Given this list of marker genes FAS, NTHL1, AAGAB, PPM1D, CHEK2, MRE11, MEFV (NCBI Gene Id 4210), BAP1, KLLN, LMNA, TWIST1, RAD51D, ATM, MITF, HMMR, PRKAR1A, RAD50 (NCBI Gene Id 10111, RAD50 double strand break repair protein), PTEN, USF3, PTPN6, MSH6, AXIN2, CTNNB1, MGMT, TGFBR2, SDHD, SEC23B, RABL3, NF1, GNAS, PALB2, ACD, ESR1, MSH3, ATR, CDK4, ZFTA, PMS1, RAD51, RAD54L, SEMA4A, NBN, POLD1, MDM2, MC1R, CDKN2B, PRLR, PMS2, WRN, COL14A1, ERBB2, SDHB, STK11, TERT, NQO2, MBD4, RPS20, MSH2, SLC6A17, SLC22A18, FGFR2, BLM (NCBI Gene Id 641), TP53, SMAD4, CASP8, BARD1, RB1CC1, MLH1, CDH1, RAD51C, EPCAM, BRIP1, PALLD (palladin, cytoskeletal associated protein), PRKN, KRAS, SDHC, TERF2IP, PIK3CA, XRCC3, AKT1, PHB1, IDH1, MUTYH, BRCA2, OPCML, CASP10, BRCA1, RNF43, PDE11A, FASLG, IDH2, POT1, BMPR1A, POLE, APC, CDKN2A, here is a description of the gene set: Neoplasm of the breast Human Gene Set: HP_NEOPLASM_OF_THE_BREAST A tumor (abnormal growth of tissue) of the breast. studied in species Homo sapiens